Given this list of marker genes ALK, here is a description of the gene set: studied in species Homo sapiens Reactome Pathway: brigatinib-resistant ALK mutants part of: Drug resistance of ALK mutants Brigatinib is a second generation tyrosine kinase inhibitor with activity against ALK. This pathway describes ALK mutants that are resistant to inhibition by brigatinib.